The following is a description of a gene set: studied in species Mus musculus from publication Chen Y, Wang X (PMID 31504780) Mouse Gene Set: MIR_6413 Genes predicted to be targets of miRBase v22 microRNA mmu_miR_6413 in miRDB v6.0 with MirTarget v4 prediction scores > 80 (high confidence targets)., and this is the list of marker genes: Matr3, Hnf1b, Rasal1, Neurod1, Nadk2, Pdgfra, Pde1a, Oxtr, Anks1, Nfxl1, Cnot6, Slc25a25, Tmem164, Dynlt1a, Mydgf, Ttc17, Zcchc14, Rap1b, Rab8a, Kif3b, Cyb561d1, Gpr151, Mix23, Camk2b, Zfp980, Mapk14, Kbtbd6, Sstr1, Insig1, Adcyap1r1, Med13, Igfbp4, Rbm3, Spon1, G6pdx, Nav2, Apob, Ugcg, 9930012K11Rik, Zfp820, Gm11545, Dmtn, Gfpt1, Dgkk, Zfp975, Ntsr1, Clcn3, Spast, Ark2c, Tmed8, Dhx33, Tmem121b, Luc7l, Fsd1l, Mrc2, Hspb7, Nefm, Rnf41, Sting1, Rnf2, Samd4b, Dmrtb1, Ccdc25, Snn, Iffo2, Snhg11 (small nucleolar RNA host gene 11), Zfp947, 2510009E07Rik, Pkdcc, Stradb, Zfp600, Tspan14, Rps15a, Rap1a, H2ax, Otud5, Rapgef2, Avl9, Lrsam1, Ipcef1, Med8, Slc16a2, Klrb1a, Xpo7, Diaph1, Atad2b, Ptger4, Scml2, Plcl2, Dlgap4, Cdh7, Dusp16, Zxdc, Sdf2, Pik3cg, Smagp, Mboat7, Rubcn, Klhl1, Agpat1, Appl2, Dynlt1b, Kcnb1, Mau2, Fam78b, Cited4, Snap91, Zxdb, Per1, Per2, Specc1, Gal3st3, Pla2g4e, Klf8, Atp13a2, 2810459M11Rik, Dock3, Mia3, Pskh1, Mecp2, Lsamp, Gorab, Cdk16, Zswim7 (NCBI Gene Id 69747), Zfp942, Ndst1, Chd5, Sema4b, Mxi1, Stc2, Tmem161b, Polr1e, Rex2, Kptn, Ago4, Prdm1, Rc3h2, Sart1, Arid5a, Zfp811, Tmem70, Lmtk2, Trim66, Depdc5, Nphp1, Dusp8, Tcf7, Blzf1, Lhpp, Polr3d, Gad1, Bcl2l11, B3gnt5, Zfp68, Ncl, Tfcp2l1, Amz1, Grik3, Fyb2, Bco1, Stx5a, Dagla, Trpm1, N4bp1 (NCBI Gene Id 97462), Fam210b, Fst, Calcr, Abcb9, Slc25a44, Mrpl45, Tmem245, Kbtbd13, Laptm4b, Zfp654, Cdkn1b, Zfp981, Cmtm4, Nemp1, Foxred2, Nlrp6, Grip1, Chmp1b2, Kcnk2, Pigm, Rasa1, Midn, Sncaip, Calhm4, Ube2k, Zfp697, Crat, Vgll3, Entpd6, Kctd21, Rmi1, Dlc1, Pgap4, Abhd13, Tmem267, Sesn1, Lmbr1l (limb region 1 like), Magi1, Gbx2 (gastrulation brain homeobox 2), Skida1, Sphkap, Il1r1 (NCBI Gene Id 16177), Taok1, Sema4a, Pml, Tada2b, Tceanc2, Klhdc9, Nova2, Fgf11, Klk10 (NCBI Gene Id 69540), Chic1, Ptprf, Apba1, Dyrk2, Trp53bp1 (NCBI Gene Id 27223), Nlk, Tpmt, Kcnip1, Acaca, Als2, Vstm4, Ebf2, Ago3, 3110082J24Rik, Vav2, Zfp446, Aldh5a1, Nup210, Plod2, Gnao1, Kif21b, Tbc1d24, Gfer, Ranbp10, Crebl2 (NCBI Gene Id 57903), Wnt8b, Cers3, Gal3st2c, Brd8, Rala, Amotl2, C1qtnf1, Mbd6, Bhlhe22, Rap2c, Mboat1, Rnf138, Ppp1r16b, Add2, Top1, Sptlc2, Map6d1, Tor2a, Reep1, Agps, Nrp2, Prss44, Zbtb37, B4gat1 (beta-1,4-glucuronyltransferase 1), Btaf1